The following is a description of a gene set: species: Mus musculus Any process that stops, prevents, or reduces the frequency, rate or extent of the chemical reactions and pathways resulting in the formation of phospholipids. Mouse Gene Set: GOBP_NEGATIVE_REGULATION_OF_PHOSPHOLIPID_BIOSYNTHETIC_PROCESS, and this is the list of marker genes: Pdgfa, Abca2, Pdgfb, Lpcat1, Slc27a1